The following is a description of a gene set: Butyrophilin (BTN) family interactions studied in species Homo sapiens Human Gene Set: REACTOME_BUTYROPHILIN_BTN_FAMILY_INTERACTIONS, and this is the list of marker genes: BTN2A1, BTN3A1, BTN3A3, BTN3A2, BTN1A1, BTN2A2, BTNL9, CD209, BTNL8, BTNL2, PPL, XDH